Given this list of marker genes PIK3R1, HRAS, KRAS, GRB2, SOS1, PIK3R2, STAT3, STAT1, PDGFRA, NRAS, PIK3CB, PIK3CA, here is a description of the gene set: PDGFRA is a type III transmembrane receptor tyrosine kinase. The extracellular domain consists of 5 immunoglobulin (IG) domains that contribute to dimerization and ligand binding. The intracellular region has a juxtamembrane domain that plays a role in autoinhibiting the receptor in the absence of ligand, and a bi-lobed kinase region with an activation loop and the catalytic cleft. Upon ligand binding, PDGFRA undergoes dimerization and transautophosphorylation at at least 11 tyrosine residues in the intracellular domain. These phosphorylated residues are binding sites for downstream effectors of PDGFRA-responsive signaling pathways. <br>PDGFRA is subject to activating mutations in a number of cancers, including gastrointestinal stromal tumors (GIST), melanoma and haematological cancers. The most prevalent mutations in PDGFRA are at residue V561 in the juxtamembrane domain, N659 in the small lobe of the kinase domain and D842 in the activation loop of the kinase domain. PDGFRA is also subject to short deletions in the activation loop segment. Acitvated forms of the protein may signal from the plasma membrane, similar to the wild type receptor, however there is also evidence that some mutants, notably D842V and V561D localize primarily to the Golgi membrane. Activated PDGFRA mutants signal constitutively in the absence of ligand. studied in species Homo sapiens Reactome Pathway: Signaling by PDGFRA transmembrane, juxtamembrane and kinase domain mutants part of: Signaling by PDGFR in disease